Given this list of marker genes PPID, VDAC2, APP, SLC25A31, SLC25A6, VDAC3, VDAC1, SLC25A5, CYCS, SLC25A4, here is a description of the gene set: Mutation-caused aberrant Abeta to VGCC-Ca2+ -apoptotic pathway. Pathway ID: N01006. Pathway type: Variant. Pathway class: nt06460 Alzheimer disease. Human Gene Set: KEGG_MEDICUS_VARIANT_MUTATION_CAUSED_ABERRANT_ABETA_TO_VGCC_CA2_APOPTOTIC_PATHWAY_N01006 studied in species Homo sapiens Pathway Definition from KEGG: APP* -> Abeta -> PPID -> MPTP -> CYCS